Given this list of marker genes RGS9BP, PDE6G, METAP1, GRK7, GNGT1, METAP2, GRK4, GNAT1, PRKCQ, RHO, GUCY2F, PDE6A, GRK1, PPEF1, RGS9, GNB5, NMT1, GNB1, RCVRN, GUCY2D, CNGB1, CAMKMT, GUCA1C, GUCA1B, CALM1, CNGA1, FNTA, SAG, NMT2, PRKCA, FNTB, PDE6B, GUCA1A, here is a description of the gene set: part of: The phototransduction cascade species: Homo sapiens Reactome Pathway: Inactivation, recovery and regulation of the phototransduction cascade To terminate the single photon response and restore the system to its basal state, the three activated intermediates in phototransduction, rhodopsin (MII), transducin alpha subunit with GTP bound (GNAT1-GTP) and phosphodiesterase 6 (PDE6) all need to be efficiently deactivated. In addition, the cGMP concentrations must be restored to support reopening of the CNG channels. This section describes the inactivation and recovery events of the activated intermediates involved in phototransduction (Burns & Pugh 2010, Korenbrot 2012).